The following is a description of a gene set: This event has been computationally inferred from an event that has been demonstrated in another species.<p>The inference is based on the homology mapping from PANTHER. Briefly, reactions for which all involved PhysicalEntities (in input, output and catalyst) have a mapped orthologue/paralogue (for complexes at least 75% of components must have a mapping) are inferred to the other species. Reactome Pathway: P2Y receptors electronically inferred by orthology from the curated human pathway part of: Nucleotide-like (purinergic) receptors studied in species Mus musculus, and this is the list of marker genes: Lpar6, P2ry1, P2ry4, P2ry2, Gpr17, P2ry10, P2ry13, Lpar4